Given this list of marker genes Mtor, Slco1b2, Prmt1, Nfe2l2, Bmt2, Mat2a, Pck1, here is a description of the gene set: studied in species Mus musculus Any process that results in a change in state or activity of a cell or an organism (in terms of movement, secretion, enzyme production, gene expression, etc.) as a result of a methionine stimulus. Mouse Gene Set: GOBP_RESPONSE_TO_METHIONINE